The following is a description of a gene set: studied in species Homo sapiens Human Gene Set: MIR5195_3P from publication Chen Y, Wang X (PMID 31504780) Genes predicted to be targets of miRBase v22 microRNA hsa-miR-5195-3p in miRDB v6.0 with MirTarget v4 prediction scores > 80 (high confidence targets)., and this is the list of marker genes: NTN4, CAMK1D, ARL6IP5, RNF207, TRPC6, BLTP3A, EPHA4, HTR2A, USP32, PPP3CA, IKZF2, ERLIN1, DNAL1, UBN2, SOX11, KDM7A, PCBP4 (NCBI Gene Id 57060), STAM, HECTD1, NECTIN3, ADI1, ACTG1, ADAM19, BCR, EBF3, CPNE8, RIN2, ADAMTS5, NEDD9, EPB41L5 (NCBI Gene Id 80242), LOX, CAMKK1, PDCD4, VPS26A, TAT, SET, MYCN, RREB1, MPZL2, QKI, ADCYAP1, ARPC5, GABARAPL1, EBF1, TMEM178A, MYO5A, ZNF543, AKAP9, MED13, NR4A2, LRRC8B, TMEM9B, IVNS1ABP, SAP30L, DLC1, SLC7A8, ZFYVE9, DAW1, LDLRAD3, UMODL1, TFEC, FOXO1, NAV3, ABHD17C, COL11A1 (NCBI Gene Id 317718), HS6ST1, CACNB2, ANKRD28, RNF170, CTNND1, ARL5B, MDFIC, ITPR2, ITGB8, SNX27, YES1, DLX6, PMP22, UBR7, IFT56, ZMYM5, PSAT1, YTHDC1, TNFRSF11B, PRDM2, ADD3, OTOR, SMAD3, SPSB4, MYRF (myelin regulatory factor), ZFHX4 (NCBI Gene Id 79776), PTGFR, DDC, TRIO, EAPP, DENND5B, CLCN2, JPH1, GLIS1, SCN2A, SERINC5, OGT, PRKD3, AGFG1, GRB10, SLC38A11, KLHL11, CAMSAP2, NET1, ASAP2, NUFIP2, UXS1, HECW2, NAA30, ATP8A1, TPM4, COMMD9, NINL, ATP1A2, KIF21A, COMMD5, USP31, DUSP6, CCDC148, AP2B1, TPR, KCNA4, PLXNA2, ARHGAP21, CSRNP2, FLI1, ANGPT2, TMEM167A (NCBI Gene Id 153339), CAMK2D, NAA15, DOCK9, AP1G1, CHAC2, MKX, HEY1, H2AX, TENT2, SSH2, MOSMO, TGFBR2, RGS7, RASSF2, PAN2, ADPGK, LRAT, RAB11FIP4, PLA2R1, ZBTB20, ABHD17B, KCNK1, ATXN2, CNTN4, PLCL2, BNIP3, OSBPL1A, FKBP3, TMEM184A, ZBTB10, DLGAP1, SMAD5, SNTB2, TDRD6 (NCBI Gene Id 221400), NUAK1, C2CD5, DYRK1A, KIF3A, RBM20, KLHL18, NFIA, MYO6, MEST, HNRNPH2, PALS1, EPS15, CORO2B, KCNK9, DENND10, ST6GALNAC3, TENT4B, ELK4, XRN1, ARHGAP6, VWA5A (NCBI Gene Id 4013), PTPN12, RAB14 (NCBI Gene Id 51730), SENP2, BICC1 (BicC family RNA binding protein 1), MAGI2, SLC30A9, FAM135A, ZBTB33, RASA1, G3BP1, RPS6KB1, NEGR1, VASN, PPP4R2, UNC119B, PLCE1, SRGAP2, USP37, NSUN4, CSMD3, WDR33, ZNF521, PXN, LAMP2, FSCN1, BTG1, ABCA1, RNF186, MAP4K4, RAD51B, FLRT3, PSD3, GJA3, RC3H1, NAA40, TULP4, COL6A5, KATNBL1 (NCBI Gene Id 91186), GMFB, MRTFB, ZNF626, SEMA6A, EXOC8, NDFIP2, CREB5, SPATS2, ERBB4, TMEM139, SRGAP1, CACNA1D, INO80, GALNT1, HIC2, CCDC25, POTEM, REV3L, SLC25A36, GLIS3, NAP1L1, RTKN, HTATSF1, SEMA3A, ABRACL, FAM174B, ZBTB6, GABARAPL2, RASA2, ETNK1, MBTD1, RCBTB1, MTF1, GFRA1, TBC1D15, TPM3, CCN1, USP46, CLCN3, TMOD2, MYSM1, HELB, NDUFA4, RIMS1 (regulating synaptic membrane exocytosis 1), UBE2W, PHACTR2, CHP1, CRKL, CITED2, CBFB, ELMO1, TRIM2, ALS2, ABCE1, APLF, ARF6 (ADP ribosylation factor 6), ADAM17, TAGLN2, ACTB, AKAP12, KLF5, ERG, RPL36A-HNRNPH2, HEPHL1, PCSK5, CASZ1, SLC5A6, UBA6, BACH2, SOX9, QSER1, NRAS, PURA, TGFB2, YTHDF2, CARMIL1, DACH1, SNX8, ABR, CACHD1, PRDM1, EIF4EBP2, IPMK, DAB2, FLNB